Given this list of marker genes PRMT5-DT, RNVU1-21, ANG, SHF, PPP6R3, MIR3120, PHLDA1, HMGN4, LINC02136, RNASE4, PARP2, LRP3, COX8CP1, TRIM41, SCAND3, PHLDA1-DT, RPS29, CLASP1, SLC27A4, LINC01719, PRMT5, GSTA4, MIR5087, here is a description of the gene set: Genes containing one or more binding sites for (PGBD5) in their promoter regions (TSS -1000,+100 bp) as identified by GTRD version 20.06 ChIP-seq harmonization. species: Homo sapiens from publication Yevshin I, Sharipov R, Kolmykov S, Kondrakhin Y, Kolpakov F (PMID 30445619) Human Gene Set: PGBD5_TARGET_GENES